Given this list of marker genes MYC, EXT1, TCEA1, RUNX1T1, NCOA2, NBN, RECQL4, COX6C, PLAG1, here is a description of the gene set: species: Homo sapiens from publication Myllykangas S, Himberg J, Böhling T, Nagy B, Hollmén J, Knuutila S (PMID 16751803) DNA copy number amplifications activate oncogenes and are hallmarks of nearly all advanced tumors. Amplified genes represent attractive targets for therapy, diagnostics and prognostics. To investigate DNA amplifications in different neoplasms, we performed a bibliomics survey using 838 published chromosomal comparative genomic hybridization studies and collected amplification data at chromosome band resolution from more than 4500 cases. Amplification profiles were determined for 73 distinct neoplasms. Neoplasms were clustered according to the amplification profiles, and frequently amplified chromosomal loci (amplification hot spots) were identified using computational modeling. To investigate the site specificity and mechanisms of gene amplifications, colocalization of amplification hot spots, cancer genes, fragile sites, virus integration sites and gene size cohorts were tested in a statistical framework. Amplification-based clustering demonstrated that cancers with similar etiology, cell-of-origin or topographical location have a tendency to obtain convergent amplification profiles. The identified amplification hot spots were colocalized with the known fragile sites, cancer genes and virus integration sites, but global statistical significance could not be ascertained. Large genes were significantly overrepresented on the fragile sites and the reported amplification hot spots. These findings indicate that amplifications are selected in the cancer tissue environment according to the qualitative traits and localization of cancer genes. Human Gene Set: MYLLYKANGAS_AMPLIFICATION_HOT_SPOT_16 Amplification hot spot 16: colocolized fragile sites and cancer genes in the 8q11.1-q24.3 region.